The following is a description of a gene set: Mouse Gene Set: GOBP_CEREBRAL_CORTEX_CELL_MIGRATION species: Mus musculus The orderly movement of cells from one site to another in the cerebral cortex., and this is the list of marker genes: Sun2, Nr2e1, Pex5, Rhoa, Psen1, Dixdc1, Pou3f3, Reln, Adgrg1, Srgap2, Rac1, Ndel1, Pafah1b1, Arx, Rnf7, Disc1, Cdk5, Dab2ip, Slit2, Fbxo45, Rtn4, Efhc1, Col3a1 (collagen, type III, alpha 1), Syne2, Lrp8, Ctnnb1, Nkx2-1, Foxg1, Mdga1, Lhx6, Ccdc141 (coiled-coil domain containing 141), Sun1, P2ry12, Mboat7, Pex13, Socs7, Egfr, Ulk4, Cul5, Dcx, Fut10, Gli3, Cdk5r2, Htr6, Pou3f2, Bmerb1, Cdk5r1, Robo1, Dab1, Fgfr1, Zmiz1, Fgf13, Wdr47, Lamb1, Lrp6 (low density lipoprotein receptor-related protein 6)